Given this list of marker genes Dlx1as, 2610005L07Rik, Tgfb2, Mthfd1l, Hoxa1, Tbx15, Six2, Smad2, Smad3, Tulp3, Nodal, Tgfbr2, Tgfbr1, Mmp16, Eif4a3, Lhx1, Fuz, Eif4a3l2, Ndst1, Tbx1, Six4, Tfap2a, Wnt9b, Rdh10, Bmp4, Tgfb3 (NCBI Gene Id 21809), Fgfr2, Ift140, Med12, Pdgfra, Fgf8, Gli3, Pax5, Grhl2, Prrx1, Slc39a3, Gas1, Hoxa2, Wdr19, Twist2, Dlx2, Six1, Eif4a3l1, Setd2, Foxc2, Runx2, Irx5, Prrx2, Mmp14, Slc39a1, Nipbl, Chst11, Gnas, Twist1, Mef2c, here is a description of the gene set: species: Mus musculus The process in which the anatomical structures of the cranial skeleton are generated and organized during the embryonic phase. Mouse Gene Set: GOBP_EMBRYONIC_CRANIAL_SKELETON_MORPHOGENESIS